The following is a description of a gene set: Human Gene Set: MODULE_424 Genes in the cancer module 424. species: Homo sapiens, and this is the list of marker genes: TLR3, FCGR2A, FCGRT, CIITA, PSG3, LILRB3, FCGR3A, LGALS3, FCER1G, APOH, FCER1A, IGLL1, MS4A2, KIR3DL1, LILRB2, TLR1, FCER2, HCP5 (HLA complex P5)